The following is a description of a gene set: species: Mus musculus Any process that starts or increases the rate, frequency or extent of stress-granule assembly, the aggregation, arrangement and bonding together of proteins and RNA molecules to form a stress granule. Mouse Gene Set: GOBP_POSITIVE_REGULATION_OF_STRESS_GRANULE_ASSEMBLY, and this is the list of marker genes: G3bp2 (NCBI Gene Id 319444), Atg5 (autophagy related 5), Caprin1, Hif1a, Ubap2l, Hsf1, G3bp1, Becn1